The following is a description of a gene set: Human Gene Set: KEGG_MEDICUS_VARIANT_MUTATION_CAUSED_ABERRANT_HTT_TO_TNF_JNK_SIGNALING_PATHWAY studied in species Homo sapiens Pathway Definition from KEGG: HTT* -> MLK2 -> MKK7 -> JNK Mutation-caused aberrant Htt to TNF-JNK signaling pathway. Pathway ID: N00992. Pathway type: Variant. Pathway class: nt06461 Huntington disease., and this is the list of marker genes: MAPK9, MAP3K10, MAP2K7, MAPK8, HTT, MAPK10